The following is a description of a gene set: studied in species Homo sapiens Human Gene Set: KEGG_MEDICUS_PATHOGEN_KSHV_VCYCLIN_TO_CELL_CYCLE_G1_S Pathway Definition from KEGG: vCyclin -> CDK4/6 -> RB1 // E2F KSHV vCyclin to cell cycle G1/S. Pathway ID: N00168. Pathway type: Pathogen. Pathway class: nt06230 Cell cycle., and this is the list of marker genes: CDK6, E2F3, RB1, E2F1, E2F2, CDK4 (NCBI Gene Id 92978)